Given this list of marker genes RGS19, GNG7, GNGT1, GNG11, RGS17, GNB1 (NCBI Gene Id 87729), GNAI3, ADRA2B, RGS4, PRKCG, GNB3, ADCY8 (adenylate cyclase 8), GNB4, PRKCB, GNG5, GNG3, GNG8, ADCY9, GNG13, ADRA2A, GNAS, GNG12, PRKCH, PRKCQ (protein kinase C theta), ADCY2, GNAI2, GNG4, GNAI1, PRKCA, PRKCD, GNG10, ADRA2C, ADCY5 (NCBI Gene Id 255218), GNB5, GNB2, ADCY1, GNAZ, GNG2, GNGT2, RGS20, ADCY4, ADCY6, RGSL1, ADCY7, RGS16, ADCY3, GNAT3, PRKCE, here is a description of the gene set: studied in species Homo sapiens G alpha (z) signalling events Human Gene Set: REACTOME_G_ALPHA_Z_SIGNALLING_EVENTS